The following is a description of a gene set: Human Gene Set: MIR6748_5P Genes predicted to be targets of miRBase v22 microRNA hsa-miR-6748-5p in miRDB v6.0 with MirTarget v4 prediction scores > 80 (high confidence targets). from publication Chen Y, Wang X (PMID 31504780) studied in species Homo sapiens, and this is the list of marker genes: RTL9 (NCBI Gene Id 57529), MEF2D, PALM, SUPT6H, CT55, ADGRA1, SDC3 (NCBI Gene Id 9672), PLIN3, TMEM108, INHBB, ASB6, SCN3B, PIERCE1, SLCO3A1, AMMECR1L, SOX2, YWHAH, TJP1, ZMIZ1, BCL7A, SORCS2, SIRPB1, NUDT7, NHERF1, BAZ1B, FGFR1, PCYT1A, NECTIN1, ZNF821, FAM167A, DTNA, TRARG1, H2BC18, PEX13, ZBTB20, MTMR3, CCDC110, CDKL4, PDE6B, TNPO3, SEM1, KLF13, TMEM95, GRIK3, EDNRB, NR6A1, SULT4A1 (NCBI Gene Id 25830), CNFN, CLEC2D, XAF1, CD37, VSIG1, LY6G5B, TCF4, FOXI2, CDC40, TIFAB, CACUL1, TET2, IQSEC2, CRHR2, CACNA1A, TRPM6, CERS6, VEGFA, EDDM3A, LYL1, ITGAV, C1RL, BMP4, RNLS